The following is a description of a gene set: studied in species Homo sapiens Human Gene Set: HP_ABNORMALITY_OF_THE_HIP_GIRDLE_MUSCULATURE Abnormality of the hip-girdle musculature, and this is the list of marker genes: LMNA, TRIM32, ANO5, VCP, SGCB